The following is a description of a gene set: studied in species Homo sapiens part of: Cytokine Signaling in Immune system Colony stimulating factor-1 (CSF1, CSF-1, also called macrophage colony stimulating factor, M-CSF) is a disulfide-linked dimer that stimulates the proliferation and differentiation of mononuclear phagocytes and the survival, proliferation, motility, and anti-inflammatory activity of macrophages. The unliganded CSF1 receptor, CSF1R (CSF-1R) is either clustered or undergoing rapid dimer-monomer transitions at the cell surface. The CSF1 dimer initially binds the D2 and D3 extracellular domains of a monomer of CSF1R. A second monomer of CSF1R then binds the CSF1:CSF1R complex and the resulting dimerization of CSF1R activates its kinase activity. CSF1R initially trans-autophosphorylates tyrosine-561 in the juxtamembrane domain, relieving negative autoinhibition of kinase activity, resulting in the trans-autophosphorylation of 7 more tyrosine residues in its cytoplasmic domain.<br>The PIK3R1 (p85alpha) regulatory subunit of phosphatidylinositol 3-kinase (PI3K) binds phosphotyrosine-723 of CSF1R, phosphorylated SRC binds phosphotyrosine-561 of CSF1R, phosphorylated CBL binds CSF1R associated with SHC, and GRB2:SOS binds CSF1R. The resulting activation of the catalytic subunit of PI3K (PIK2CA,B,G) produces phosphatidylinositol 3,4,5-trisphosphate which recruits effectors containing pleckstrin homology domains (PH domains) such as PKB (also called Akt) to the plasma membrane. Pathways activated by PI3K appear to both enhance proliferation, survival, and migration of macrophages and, via induction of miR21, suppress the inflammatory response by targeting mRNAs encoding multiple proinflammatory molecules.<br>Phospholipase C gamma2 (PLCG2) binds phosphotyrosine-723 of CSF1R, hydrolyzes phosphatidylcholine to yield choline phosphate (phosphocholine) and diacylglycerol, and promotes survival and differentiation of macrophages via PKCdelta (PRKCD) (inferred from mouse homologs).<br>GRB2 bound to SOS1 (GRB2:SOS1) transiently interacts with phosphotyrosine-699 of CSF1R. SOS1 promotes the exchange of GDP for GTP by KRAS, activating the RAS-RAF-ERK1,2 pathway that causes proliferation of macrophage precursors (inferred from mouse homologs). CBL transiently associates with and ubiquitinates the CSF1R, then is deubiquitinated and returned to the cytoplasm (inferred from mouse homologs).<br>Phosphorylated CSF1R also recruits STAT1 and STAT3, which are then phosphorylated (inferred from mouse homologs). The role of phosphorylated STAT1,3 in signaling by CSF1R is incompletely characterized.<br> CSF1R is a target for therapeutics, such as imatinib. Reactome Pathway: Signaling by CSF1 (M-CSF) in myeloid cells, and this is the list of marker genes: UBA52, SHC1, STAT1, HCK, GAB2, CSF1R, RPS27A, CSF1, UBB, PLCG2, GRAP2, YES1, FYN, INPPL1, GRB2, GAB3, KRAS, PIK3R1 (phosphoinositide-3-kinase regulatory subunit 1), SOS1, PIK3CB, LYN, THOC5, STAT3, UBC, INPP5D, IL34, PTPN11, PIK3CA, SRC (NCBI Gene Id 6714), PIK3CD, CBL